The following is a description of a gene set: studied in species Homo sapiens Human Gene Set: PID_NFAT_TFPATHWAY from publication Schaefer CF, Anthony K, Krupa S, Buchoff J, Day M, Hannay T, Buetow KH (PMID 18832364) Calcineurin-regulated NFAT-dependent transcription in lymphocytes, and this is the list of marker genes: NFATC3, NFATC2, GATA3, IFNG, FOSL1, EGR1, EGR2, CD40LG (CD40 ligand), SLC3A2, PTPRK, PRKCQ, JUNB, RNF128, TBX21, EGR3, BATF3, PPARG, FOXP3, GBP3, IL2RA, CDK4, IRF4, PTGS2, IKZF1, IL5, CXCL8, PTPN1 (protein tyrosine phosphatase non-receptor type 1), MAF, IL3 (interleukin 3), E2F1, IL4, IL2, CASP3, FOS, NFATC1, TNF, ITCH, POU2F1, CBLB, FASLG, JUN, CSF2, DGKA, CTLA4, EGR4